Given this list of marker genes Acsm4 (acyl-CoA synthetase medium-chain family member 4), Acsm5, Acsm2, Glyatl3, Acsm1, here is a description of the gene set: electronically inferred by orthology from the curated human pathway part of: Amino Acid conjugation studied in species Mus musculus This event has been computationally inferred from an event that has been demonstrated in another species.<p>The inference is based on the homology mapping from PANTHER. Briefly, reactions for which all involved PhysicalEntities (in input, output and catalyst) have a mapped orthologue/paralogue (for complexes at least 75% of components must have a mapping) are inferred to the other species. Reactome Pathway: Conjugation of carboxylic acids